The following is a description of a gene set: from publication Ramirez K, Chandler KJ, Spaulding C, Zandi S, Sigvardsson M, Graves BJ, Kee BL (PMID 22608498) species: Homo sapiens Genes down-regulated in hematopoietic stem cells versus granulocyte-monocyte progenitors. Human Gene Set: GSE37301_HEMATOPOIETIC_STEM_CELL_VS_GRAN_MONO_PROGENITOR_DN Expression profiling of Rag2-deficient Ets1++ and Rag2-deficient Ets1-- mature NK cells and WT bone marrow progenitors, WT T cells, and WT Pro B cells, and this is the list of marker genes: FAM114A1, RPN2, SDCBP, ACOT11 (NCBI Gene Id 91515), IL10RA, SQSTM1, GRAMD1C, FOSL2 (FOS like 2, AP-1 transcription factor subunit), RTN4, PCTP, MYO1F, RBPJ, GLA, ST3GAL2 (ST3 beta-galactoside alpha-2,3-sialyltransferase 2), ACTG1, EHD4, HMGCR, FKBP5, BLTP3B, SPOCK2, ADAP1, DUSP7, LDAF1, BAZ1A, PLP2, MLF1, LPCAT2, ELL, ZC2HC1A, FBXO33, ATP2B4, EZR, REEP5, SLC16A6, DOP1B, TCN2, CYSLTR1, TMPRSS11E, FBXO30, RABGEF1, NAV2, TLN1, TEC, SEC14L1, ITGA1, RAPH1, CRIP1 (NCBI Gene Id 1396), ZBTB32, STAP1 (NCBI Gene Id 26228), ANXA6, WDR26, CDKN1A, ATF3, GALC, MALT1, PIP4P2, MAP3K12, FAM185A, NIPSNAP3B, DNAJC12, HPSE, ARL13B, PMAIP1, TMEM30A, CERS4, GNB4, CPT1A, ATP6V0A1, BATF, CLIP3, IQCE, POMT2, HSP90B1, RELL1, GFI1, TOB2, PON3, ITGA4, ID2, HMGCS1, GALNT1, UBL3, S100A6, VSTM2A, MAP2K3, FLNA, NR3C1, TENT5A, NAAA, CAPG, PLA2G15, HERPUD1, NDRG1, ACAP3, ITGAV, ACLY, MCU, CSRP2, NPNT, KLF10, PBX3, KIT, ADARB1, TRIM46, TBC1D31, AR, SMCO4, MARVELD2, AKAP1, EBI3, SLC43A3, EPCAM, DKKL1, SEC24D, SIK1, CCR4, GRN, KDSR, AKAP12, PPP4R4, SORL1, MIR24-1, YWHAB, SYNE2, MFGE8, GAS2, KLF6, YPEL2, IFFO2, TFRC (NCBI Gene Id 7037), CCDC112, S100A11, RPS6KA5, NUCB1, TRIM36, TMTC2, RAI14, DPY19L3, SIT1 (NCBI Gene Id 27240), PCBP4, DHX32, TNF, TMTC3, RASGRP1, IRAK3, SORBS1, TRPM4, GNG2, C1QTNF12 (NCBI Gene Id 388581), MAPKAPK3, IMPA2 (inositol monophosphatase 2), TBC1D9B, BIVM, MYO1D, PSEN2, AXIN2, PRKAR2A, AKAP7 (A-kinase anchoring protein 7), DOCK5, CEBPB (NCBI Gene Id 90277), AFF4 (ALF transcription elongation factor 4), GLUD1, MMP9, FARP1, STX12, TASP1, MARCHF8, FAM110A, PTPN13, MANSC1 (NCBI Gene Id 54682), PIM1, TMEM43, MAGI1, IRS2, ATXN1, IL5